Given this list of marker genes Igf1, Safb, Cyp3a41a, Hid1, Pcsk6, Myt1, Rdh19, Cyp1a2, Stc2, Lrat, Hfe, Cyp1a1, Dio3, Rbp4, Pde8b, Slc16a10, Disp1, Rdh7, Hsd17b7, Duox2, Clcn2, Hsd17b8, Bbs1, Ces2a, Mme (membrane metallo endopeptidase), Prlhr, Dio1, Plekha1 (pleckstrin homology domain containing, family A (phosphoinositide binding specific) member 1), Crym, Tpo, Ces1f, Bmp2, Sult1e1, Akr1c21 (NCBI Gene Id 77337), Hsd11b1, Sult2a8, Plb1, Ffar3, Stard3, Ugt1a1 (UDP glucuronosyltransferase 1 family, polypeptide A1), Sult1a1, Akr1c13, Adm, Ren1, Arnt, Hsp90b1, Dgat1, Dgkq, Egr1, Sp1, Adh6a, Mir205hg, Lhcgr, Rdh11, Nr5a2, Hsd3b6, Scg5, Furin, Srd5a1 (steroid 5 alpha-reductase 1), Iyd, Hsd17b12, Il4i1, Dgat2, Ddo, Slc30a8, Hsd3b8, Ace, Retsat, Enpep, Crabp2, Cyp27b1, Adh1, Sult2a3, Duoxa1, Slc30a5, Ugt2b35, Cpa3, Cyp26b1, Cyp1b1, Ctsb, Asmt, Slc26a7, Rdh12, Cga, Akr1c20, Lcn5, Stat5b, Hsd17b2, Chst10, H6pd, Slc5a5, Gcnt4, Ace2, Hsd3b5, Ctsk, Cyp3a16, Mep1a, Atp6ap2, Aldh8a1, Hpn, Cpe, Gnb3, Cyp26a1, Dhrs4, Ugt2b36, Lipe, Igf2, Prep, Cyp2w1, Akr1c18, 2610005L07Rik, Cpa4, Rbp1, Sult2a6, Ugt1a7c, Akr1c6, Slc16a2, Hsd17b3, Ces2c (NCBI Gene Id 234671), Cyp3a11, Aldh1a1, P4hb, Aldh1a3, Bco2, Nr5a1, Prcp, Sult2a5, Klf9, Ugt2b1, Gfi1, Akr1c14, Star, Bmpr1b, Cyp11b2, Ednrb, Hsd3b3, Sgpl1, Ces1d, Cyp2s1, Akr1b1, Awat2, Rdh14, Prmt3, Dhrs3, Wnt4, Gm2044 (NCBI Gene Id 100039095), Srd5a2, Rdh9, Ghr, Dhrs11, Shh, Ptpn11, Anpep, Ppargc1a, Schip1, Lep, Foxa1, Dkk3 (dickkopf WNT signaling pathway inhibitor 3), Duoxa2, Esr1, Sdr16c5, Pcsk1n, Rdh10, Akr1c12, Pcsk2, Spp1, Sult2a2, Hif1a, Zmpste24, Cyp26c1, Corin, Rdh5 (NCBI Gene Id 19682), Rpe65, Strap, Pcsk5, Yipf5, Agt, Cyp2c55, Ece2, Aldh1a2, Rdh1, Slco4a1, Inhba, Stub1, Aldh1a7, Hsd3b4, Rest, Tg, Med1, Hsd17b11, Kcnj6, Cyp17a1, Dab2, Pnpla2, Enpp1, Comt, Chst8, Akr1c19, Bco1, Adh4, Adam10, Cyp3a44, Rdh8, Hsd3b1, Hsd3b2, Nr3c1 (nuclear receptor subfamily 3, group C, member 1), Nfkb1, Crhbp, Pcsk4, Dhrs9, Fshr, Ces2e, Sdr9c7, Cyp46a1, Pdgfra, Aanat, Por, Dhrs7, Hsd3b9 (NCBI Gene Id 100043461), Ces1e, Gal, Ctns (cystinosis, nephropathic), Ide, Cyp3a41b, Gh (NCBI Gene Id 14599), Slco1c1, Adh6b, Scp2, Fdx1, Reln, Psg18, Pcsk1, Kcnma1, Dio2, Ece1, Rdh16, Tiparp, Ugt2b5, Cyp11a1 (cytochrome P450, family 11, subfamily a, polypeptide 1), Akr1cl, Cyp21a1, Rdh16f2, Afp, Cyp2d22, Tcf7l2, Cacna1a, Cyp27a1, Sult2a4, Ghrhr, Hsd17b6, Akr1d1, Ero1b, Ins2, Hsd17b4, Foxe1, Ctsl, Htt, Sult2a1, Adh7, Igf1r, Bmp6, Eef1ece2, Selenom, Hsd17b1, Scarb1, Cyp19a1, Cacna1h, Pax8, Cyp11b1, Pnlip, Sult1b1, Rdh13, Hsd17b10, Bmp5, Atp1a1, Cpq, Scnn1b, Sult2a7, Naglu, Gata3, Papss2, here is a description of the gene set: studied in species Mus musculus The chemical reactions and pathways involving any hormone, naturally occurring substances secreted by specialized cells that affects the metabolism or behavior of other cells possessing functional receptors for the hormone. Mouse Gene Set: GOBP_HORMONE_METABOLIC_PROCESS